The following is a description of a gene set: Caspase activation via Death Receptors in the presence of ligand species: Homo sapiens Human Gene Set: REACTOME_CASPASE_ACTIVATION_VIA_DEATH_RECEPTORS_IN_THE_PRESENCE_OF_LIGAND, and this is the list of marker genes: FAS, CASP8, FASLG, TICAM2, RIPK1, TNFSF10, CFLAR (CASP8 and FADD like apoptosis regulator), LY96, TNFRSF10B, TRADD, CD14, TRAF2, TICAM1, TLR4, FADD, TNFRSF10A